Given this list of marker genes Smad2, Tal2, Dnaaf3, Ptpn12, Lep, Cacna2d2, Stat5b, Ghrh, Pou1f1, Cdh4, Mustn1, Ahr, Lncpint, Ncapg2, Sema5b, Gas1, Daxx, Nog, Psap, Hdac3, Cited2, Spag9, Six4, Plxna4, Igfbp1, Mfsd2a, Gnasas1, Plaa, Men1, Foxc1, Wnt2, Hhex, Fgf2, Raph1, Col3a1, Fgfr2, Mir682, Eif2b2, Nek1, Xpa (xeroderma pigmentosum, complementation group A), Kdr, Suv39h1, Wwtr1, Azgp1, Hamp2, Clic4, Wnt11, Ntrk3, Ncor1, Ngf, Fendrr, Bcl11a, Cd2ap, Kmt2d, Chrnd, Dmd, Sox10, Socs2, Igf2, Ube3a, Plg, Agt, Tnr, Arih2, Cyfip1, Mir124a-2, Pou5f1, Cacna1c, Celf1, Actn3, Adrb2, Tomm70a, Sox9, Odad3, Foxc2, Edn1, Pcdh15, Smo, Nat8f3, Cdk1, Cntnap2, Slc4a10, Tnfaip6, Lamb2, Stk3, Cldn18, Bnc2, Ptch1, Ihh, Trpv2, Tnc, Plxna1, Ar, Map2, Slc1a2, Sall4 (NCBI Gene Id 99377), Spr, Plau, Sav1, Stat3, Fgf13, Eif2ak4, Helt, Bbs4 (NCBI Gene Id 52291), Rarg, Pex5, Kdf1, Gdf15 (NCBI Gene Id 23886), Syt17, St8sia2, Colq, Fgf7, Wnt7b, Bcl2l11, H3f3b, Kcnk2 (NCBI Gene Id 98453), Gsk3b, Lgr6, Ski, Dll1, Tyms, Cpne5, Cops2, Ctdp1, Scnn1b, Rgs4, Gata3, Prickle1, Por, Nrp1, Wnt5a, Zfp36l1, Prmt2, Rxra, Efna5, Ghsr, Foxs1, Dlk1, Lin7b, Tbx1, Sfrp2 (secreted frizzled-related protein 2), Lrp4, Flrt1, Igf1, Mtm1, Ly6e, Add1, Ulk2, Foxo3, Ppp2r3a, Epb41l5, H3f3a (H3.3 histone A), Mtpn, Bmpr1b (bone morphogenetic protein receptor, type 1B), Hdac2, Fbln5, Cela1, Tmem182, Heg1, Rgma, Flt3, Dusp6, Cxcr4, Ncoa3, Eif4g2 (NCBI Gene Id 77989), 2810429I04Rik (RIKEN cDNA 2810429I04 gene), Sin3a, Dscam, Mtor, Tll2, Prox1, Arid2, Edn3 (NCBI Gene Id 13616), Atxn2, Vps13a, Ptn, Zmpste24, Mir205hg, Icmt, Cdk5, Tgfbr3, Map3k13, Wnt7a, Fgf10, Golga4, Fkbp8, Spg21, Nipbl, Creb1, Arx, Zfp568, Ghr, Tcf7l2, Slc25a4, Tmed2, Myf6, Rarb, Wdtc1, Slc12a2, Nrn1l, Mir124a-1, Eif4h, Rtf1, G6pd2, Msx2 (msh homeobox 2), Fshr, Mir489, Ubtfl1, Pdgfra, Meg3, Gli1, Chd7, Yap1, Klf5, Lin7a, Adnp, Fgf20, Ostn, Dip2b, Barhl2, Cpne1, Ankrd26, Tfap2c, Ppara, Ndel1, Wnt3, Snhg15, Pou4f3, Atp8a2, Kif26b, Gap43, Ptx3, Lhx1, Iqgap1, Sfrp1, Atn1, Hsf1, Itsn2, Sh3pxd2b, Col6a1, Gdf9, Scaper (S phase cyclin A-associated protein in the ER), Sh3glb1, Ybx3, Vcl, Cfl1, Bin3, Pls1, Ddx39b, Adprhl1 (NCBI Gene Id 234072), Cacng7, Prlr, Ttl, Cobl, Syt4, Mir208a, Lmx1b, Tgfb2, Ttc8 (NCBI Gene Id 76260), Ncam1, Col27a1, Fgf8, Sall1, Impact, Prkg1, Ccn3, Macf1, Lgmn, Serpine1, Fgf9, Tnn, Nkx2-5, Mecp2, Cxadr, Vegfa, Insr, Tex19.1, Notch1, Rnd2, Gata6, Clstn3, Tbce, Brd4, Mir133a-1, Mbd5, Tbx20, Adcy10, Htra2, Sema4d, Cga, Camk2d (NCBI Gene Id 77170), Sbds, Pdgfrb, Wdr36, Pou3f2, Cflar, Otoa (otoancorin), Mapt, Ptprs, Plac1, Mycbp2, Atg16l1, Clasp2, Alkbh1, Sfrp5, Sirt6, Ccr5, Agr2, Gpd2, Hmga1, Enpp1, Matn1, Hoxa5, Six3, G6pdx, Chst11, Bloc1s6, Islr2, Zfx (zinc finger protein X-linked), Hoxa11, Mmp13, Igf1r, Taf10, Selenom (selenoprotein M), Map1b, Llph, Dysf, Mir675, Akt1, Ercc6, Aaas, Gmnc, Gigyf2, Aurka, Alms1, Gins1, Tgfbr2, Sgpl1, Rmi1, Septin7, Smad4, Rps6kb1, Cdh1, Nr5a2, Ssna1 (SS nuclear autoantigen 1), Afdn, Zfp830, Krtap21-1, Grn, Fgf1, Meis1, Vps54, Slc12a5, Evc, Kcnj8, Slc6a3, Slit3, 9630013A20Rik, Bcl9, Ptk7, Ppard, Plekha1, Ednra, Mex3c, Pum2, Chek1, Igsf10, Npr2, En1, Myo5b, H19, Nrk, Omg, Wwc1, Ankrd11, Fkrp, Trim28, Grhl2, Thbs3, Brinp3, Dyrk1a, Prkcz, Drd2, Ezh2, Gpat4, Jarid2, Emx1, Pafah1b1, Fzd9, Selenon, Flrt3 (NCBI Gene Id 77649), Rara, Fmn1, Pkm, Sgca, Bmp10, Flvcr1, Slc23a2, Xirp1, Kdm1a, Cdkn1a, Nrp2, Syt2, Spag6l, Spag6, Abl1, Ang2, Bmpr1a, Mme, Pten, Mir133a-2, Ttc3, Smurf1, Ilk, Pin1rt1, Tnks2, Dhcr7 (7-dehydrocholesterol reductase), Gnat2, Fn1, Atf2, Crhr2, Garem2, Sp2, Gsk3a, Acvr2b, Stk11, Apc, Foxp1, Myocd, Tbx2, Lats1, Nlgn4l, Apba1, Sema6c, Itgb1, Large1, Spry2 (sprouty RTK signaling antagonist 2), Lats2, Mir449c, Pdlim5, Sema6d, Plag1, Comp, Erbb4, Rc3h2, Sptbn4, Zfp950, Tnfrsf12a, Kdm2a, Parp2, Dmbx1, Pim1, Smpd3, L1cam, Mstn, Dag1, Haglr, Ift80, Smad1, Afg3l2, Cxcl12, Six1, Rab21 (NCBI Gene Id 216344), Rbbp6, Apod, Jade2, Hnf1b, Dbnl, Ppp1r13l, Mir34b, Gpx4, Gpr149, Etnk2, Gnat1, Nr3c1, Ifrd1, Med1, Pcnt, Ezr, Atrx, Ier3ip1, Vil1, Ist1, Adra1a (NCBI Gene Id 11549), Pak1, Auts2, Mapk14, Dcaf13, Gins4, Lin7c, Mkks, Areg, Mst1, Pin1, Sox2, Rgs2, Kmt2c, Mymk, Nin, Atp1a3, Disc1, Tarbp2, Ulk1, Tmem38b, Abl2, Col14a1, Spg11, Stil, Poc1a, Myoz1, Dclk1, Postn, Map7, Abcc1, Prlh, Reg1, Sgip1, Ercc5, Pik3ca, Dspp, Adrb1, Rln1, Gja1, Spart, Kdm5b, Sox15, Galnt3, Yy1, Gnas, Limk1, H2-Q2, Nkd1, Nbn, Ascl3, Ghrhr, Wdr48, Ccm2, Shtn1, Sema3a, Myh10, Fbxw10 (NCBI Gene Id 544784), C9orf72, Bmp4, P2rx5, Pdzd11, Stc1, Psapl1 (prosaposin-like 1), Guca2b, Rims1, Dicer1, Adarb1, Cyp19a1, Pelo, Hamp, Dcx, Coa5, Smad7, S1pr1, D130043K22Rik, Slc25a25, Atrn, Dlg1, Ints1, Ikzf1, Mef2c, Trp53, Stra6, Zp3, Zfp640, Nedd4l, Hdac6, Sash3 (NCBI Gene Id 74131), Thbs1, Draxin, Tmem108, Pax7, Hlx, Chrna1, Cdkn1c, Mir34c, Ctnnb1, Crabp2, Sohlh2, Hmga2, Fgfr3, Gli3, Ereg, Apba2, Slit1, Map2k4, Sos1, Myod1, Sik3, Apoe, Ccnd2, Arid5b, Prkdc, Capn3, Cpne6, Pygo2, Tshr, Tns2, Hoxd13, Ninj2, Ccm2l, Epha7, Hey2, Ccnb1, Acacb, Fto, Shbg, Mir1a-2, Mapk11, Adm, Tbx5, Tgfbr1 (transforming growth factor, beta receptor I), Plcb1, Cpq, Prkn, Il7, Esrrb, Synb, Gpam, Dmbt1, Nppc, Mir449b, Hesx1 (NCBI Gene Id 15209), Ptpn11, Ryk, Rtn4r, Ndn, Rtn4, Klf2, Gh, Dipk2a, Mir449a, Atf5, Rpl29, Nkx6-1 (NCBI Gene Id 18096), Akirin1, Tenm4, Syt3, App, Gpr21, Sh3gl2, Sema3g, Ccl11, Rai1, Hopx (NCBI Gene Id 74318), Ppib, Slc39a12, Syt1, Rbm10, Cd9, Cav3, Trp73, Ecm1, Slitrk6, Mag, Adam15, Brinp2, Cttn, Wt1, Lrp1, Bcl2, Mdk, Mapk1, Med12, Trip10, Lhx2, Hoxd11, Ddr1, Robo1, Rnf6, Shh, Rxrb, Vangl2, Zmiz1, Mfsd8, Lpar3, Npy1r, Nrg1, Fubp1, Pak6, Tbl1xr1, Rasal2 (NCBI Gene Id 320357), Ctr9, Aspm, Prkar1a, Slc9a6, Mt3, Gli2, Smarca4, Cpne9, Pi16, Wwc2, Sod1, Myh6, Ndufs6, Vps13b, Garem1, Kat2a, Zfyve27, Dio3, Arhgap32, Gas2, Olfm1, Chaserr, Setdb1, Nfix, Bmpr2, Smad3, Slco1a6, Atm, Fes, Rspo2, Dnm2, Gins3, G6pc1, Eppk1, Srf, Cox10, Fosl2, Edn2, Pou4f2, Tiam1, Megf8, Sema7a, Bcan, Llgl2, Wdr11, Slit2, Rbp4 (retinol binding protein 4, plasma), Anxa1, Fxn, Spry1, Kdm6a, Zfp418, Ptger4, Sirt1, Brca2, Adra1b, Cd81, Vgll4, Ninj1, Stc2, Akap13, Arhgap4, Csf1, Tmtc3, Picalm, Ntn1, Fdps, Zpr1, Sorbs2, Mgll, Lepr, Musk, Slitrk1, Trpc5, Alcam, Dvl1, Palb2, Ttn, Tsc22d4, Xrcc2, Lrp6, Siah1a, Pde4d, Adrb3, Csf1r, Sema4f, Dusp10, Kpna1, Rdh10, Rufy3, Fzd7, Spaar, Serp1, Carm1, Ctc1, Plec, Actr3, Bdnf, Wnt10b, Sema3f, Plac8, Hbegf, Fgfr1, Unc79, Rad51b, Nlgn3, Nanog, Gpx1, Rnf157, Mcub, Ccn4, Stk4, Rims2, Gdi1, Cdkl3, Acvr1c, Sptbn2, Ep300, Hnrnpk, Col9a1, Stat5a, Cer1, Src, B4galnt2, Twf2, Ptgfrn, Esr1, Gata4, Cadm1, Ehmt2, Drd3, Amh, Gje1 (gap junction protein, epsilon 1), Pantr2, Gm34220, Cst5, Trim46, Anapc2, Cdkl5, Dbn1, Rbpj, Slc6a4, Stk40, Pkdcc, Ext1, Agtr2, Mesp1, Cyfip2, Gamt, C3, Agrn, Bbs2, Norad (non-coding RNA activated by DNA damage), Cdkn1b, Unc13a, Rpl4, Ercc1, Apoa5, Taf8, Mul1, Sco1, Gjd4, Rag2, Comt, Hdgfl2, Wasf1, Rasal1, Lzts2 (NCBI Gene Id 226154), Notch2, Akp3, Fstl4, Tgfb1, S100b, Itga4, Zfpm2, Duox2, Usp9x, Akap6, Plxna3, Ddr2, Pthlh, Pmp22, Il6ra, Phlda2, Mael, Nrn1, Gdf5, Zeb2, Wnt3a, Mymx, Ercc2, Ptk2, Sema5a, here is a description of the gene set: studied in species Mus musculus Mouse Gene Set: GOBP_DEVELOPMENTAL_GROWTH The increase in size or mass of an entire organism, a part of an organism or a cell, where the increase in size or mass has the specific outcome of the progression of the organism over time from one condition to another.